The following is a description of a gene set: Flared nostrils Human Gene Set: HP_FLARED_NOSTRILS species: Homo sapiens, and this is the list of marker genes: BRCC3, CAMTA1, SIN3A, CDC42, ANKRD17, TCF4, NAA10, USP9X (NCBI Gene Id 8239), SMOC1, PDHA1